The following is a description of a gene set: Catalysis of the reaction: a triacylglycerol + H2O = a diacylglycerol + a fatty acid + H+. Mouse Gene Set: GOMF_TRIACYLGLYCEROL_LIPASE_ACTIVITY species: Mus musculus, and this is the list of marker genes: Apoc2, Lipg, Lipe, Dagla, Pnpla3, Pnpla2, Pnpla1, Ddhd2, Abhd5, Apoh, Aadac, Lipn, Ces1d, Gpihbp1, Pnpla5, Lpl, Daglb, Pnliprp1, Pnliprp2, Apoc2l, Cel, Lipf, Pnlip, Apoa5, Lipc (NCBI Gene Id 15450), Plb1, Abhd2